Given this list of marker genes Sox6, Fgf4, Mapk14, Pkd1, Ror2, Uncx, Mycn, Col2a1, Otor, Thra, Sulf1, Ccn2, Bmpr1b, Myf5 (NCBI Gene Id 320915), Sox9, Fgf6, Wnt7a, Sox5, Col11a1, Barx2, Acan, Tgfb2, here is a description of the gene set: Mouse Gene Set: GOBP_CARTILAGE_CONDENSATION species: Mus musculus The condensation of mesenchymal cells that have been committed to differentiate into chondrocytes.